The following is a description of a gene set: Any process that modulates the frequency, rate or extent of protein localization to nucleus. studied in species Homo sapiens Human Gene Set: GOBP_REGULATION_OF_PROTEIN_LOCALIZATION_TO_NUCLEUS, and this is the list of marker genes: BMP4, KAT7, BYSL, YAP1, NFKBIA, CCT3, EP300, TARDBP, SIRT6, TGFB2, FLNA, IPO5, SUMO1, SUMO3, RAN, CDK1, LMNA, GLI3, PLK1, LIMK2 (LIM domain kinase 2), LAMTOR5, CCT6A, SHH, TRIM8, HYAL2, CCT2, SMO, EI24, CTNNA1, MFHAS1, CDH1, MTOR (NCBI Gene Id 2476), PSEN1, LILRB4, EPM2A, TESK1, MAVS, PRKD1, CD2AP, SIN3A, GLIS2, TPR, TFRC, CARD10, FERMT2, ZC3H12A, IFNG, LATS1, ZPR1, CREBBP, PARP1, UBR5, ECT2, INS, ANGPT1, TMEM98, PRKCD, PIN1, PPP3CB, SUFU, APOD, CHP1, DMAP1, RAB23, DCLK2, CACNB4, IPO7, TGFB1, NGFR, CCT4, CCT7, FBXO4, YWHAB, CDKN2A, NF1, FERMT1, JUP, NF2, UFM1, PARP9, TERT, CABP1, ZIC1, NPM1, HSP90AA1, EDN1, WWTR1, BAG3, PINX1, CLDN18, MEPCE, CCT5, EIF2AK3 (NCBI Gene Id 9451), HCLS1, LARP7, TRIM29, NVL, TCP1, ORMDL3, JAK1, PARK7, SRC, HDAC3, SUMO4, GLUL, STK11, CD36, PIK3R1, YWHAZ, MAGED1, LZTS2, NUP58, PYHIN1, LATS2, CDK5RAP3, NMD3, EFCAB7, TRIM40, PKIA (cAMP-dependent protein kinase inhibitor alpha), ATP13A2, GSK3B, OTUD7B, MCRS1, MDFIC, CWH43, DTX3L, RASSF5, TRIM28, LEP, SESN2, MAPK14, F2, PIK3R2, RBM22, MARK3, XBP1, TCF7L2, FYN, AKT1, PKIG, ILRUN, CHP2, POLR1A, SMAD3, CCT8, TYK2, APP, JAK2